Given this list of marker genes PTPRC, FOXJ1, CD46, C4BPA, SUSD4, CR1L, HPX, CR2, FCER2, TNF, CR1 (NCBI Gene Id 1378), PTPN6, FCGR2B, LTA, TREM2, C4BPB, here is a description of the gene set: Any process that modulates the frequency, rate, or extent of a humoral immune response mediated by circulating immunoglobulin. Human Gene Set: GOBP_REGULATION_OF_HUMORAL_IMMUNE_RESPONSE_MEDIATED_BY_CIRCULATING_IMMUNOGLOBULIN species: Homo sapiens